Given this list of marker genes KY, FBXL4 (F-box and leucine rich repeat protein 4), OBSCN, COQ5, ALG14, POLRMT, CLCN6, HMGCR, DYNC1H1, here is a description of the gene set: Type 2 muscle fiber predominance An abnormal predominance of type II muscle fibers (in general, this feature can only be observed on muscle biopsy). Human Gene Set: HP_TYPE_2_MUSCLE_FIBER_PREDOMINANCE species: Homo sapiens